Given this list of marker genes KAT6A, BRPF3, BRD1, KAT7 (NCBI Gene Id 63437), KAT6B, BRPF1, ING5, MEAF6, here is a description of the gene set: studied in species Homo sapiens A multisubunit complex that catalyzes the acetylation of histone H3. Human Gene Set: GOCC_H3_HISTONE_ACETYLTRANSFERASE_COMPLEX